Given this list of marker genes GYPC, CCL1, MS4A6A, MTMR14 (myotubularin related protein 14), GPRIN1, PERP, APBB2, CCNL1, AFF1, ATF3, LRRC23, CHMP2A, KATNBL1, MITD1, OTUD7B, PDZK1 (NCBI Gene Id 96133), GRB2, HMGN5 (high mobility group nucleosome binding domain 5), SOD2, PRRT1, SLAMF1, PTPN11, LMAN1L, H2AC25, STXBP3 (syntaxin binding protein 3), ZNFX1, NUB1, UBL7, GTPBP2, TLCD4, SAMSN1, SLC22A3, IER5, TXK, ZDHHC5, SLC8A2, NOTCH2, PFN3, GUCA1A, CD200, GBP7, COL5A3, GINM1, SFTPA1, DUSP11, VSX1, MARK4, HDHD2, UPF2, TRMT1L, ATP1B2, ADRA1A, G3BP2, ASB16, ALPK2, RUSC2, TXNL1, SPTLC2, ELL2, ZNF18, TDRD7, CD38, RPS6KA2 (NCBI Gene Id 6196), CST7, ME1, FBLN5, TANC1, ARF4, ITGA4, CLCN5, PHC2, TLX2, TNFRSF1A, PRDX5, TSPAN33, PIK3AP1, COX17, MYBL1, GABRR1, MFSD1, LDLR, CHTOP, PHGR1, ZNRF1, PI4K2A, DNER, BCKDHB, PRRC1, RIBC2, FBXW11, OAS2, ELOC, BHLHA15, CCDC120, DNAJC21, TTI2, MYD88, DSCAML1, ETNK1, NID1, KEAP1, DLX1, DNAJB11, HOXA5, KATNA1, EIF2S2, GAPDHS, KTN1, ACTN1, IDO2, IL10RB, HOXA11, NAA11, PDE4B, VCAN, IL23A, RUFY3, PIP5K1B, EYA4, CHD1, SIX1, KDR, PRKD1, RAB33B, GBP4 (NCBI Gene Id 115361), CBLN1, CHM, TNFRSF8, SLITRK1, PLCL2, IFNAR2, USP15, CLN5 (NCBI Gene Id 1203), STARD5, POGLUT1, LCE2B, MAGEA11, CDH13, MTHFD2 (methylenetetrahydrofolate dehydrogenase (NADP+ dependent) 2, methenyltetrahydrofolate cyclohydrolase), BST2, NFATC2IP, DLL4, SERTAD1, PRPF38A, PTPN13, NFKB1, LCE3B, IL18, PTPRE, CPSF2, PLEKHA6, MMP14, SFRP1, ELAPOR1, WASHC4, PALLD, SLC17A1, PLAA, LY6G6D (lymphocyte antigen 6 family member G6D), CSF1, PML, SUZ12, NMD3, ADHFE1, FOXP1, OSTF1, SPAG7, GLYCTK, MACROD2, IL1RN, PPP1R2P1, RNFT1, TXN, LIN9, PAWR, PSMA2, DDA1, BCL9, TUT1, TGM2, BFAR, CD47, DRC3, C1QL3, HNRNPD, CPD, CCNB3 (cyclin B3), IGBP1, TBK1, FRMD6, ZNG1B, PYY, CUTC, TAB2, CLDND1, SNX10, KANSL1L, PTGES, GLB1L, NAMPT, here is a description of the gene set: studied in species Homo sapiens Genes down-regulated in comparison of control dendritic cells (DC) at 4 h versus those stimulated with CpG DNA (TLR9 agonist) at 4 h. from publication Amit I, Garber M, Chevrier N, Leite AP, Donner Y, Eisenhaure T, Guttman M, Grenier JK, Li W, Zuk O, Schubert LA, Birditt B, Shay T, Goren A, Zhang X, Smith Z, Deering R, McDonald RC, Cabili M, Bernstein BE, Rinn JL, Meissner A, Root DE, Hacohen N, Regev A (PMID 19729616) mouse primary BMDCs were stimulated with tlr ligands and gene expression changes were profiled on Affymetrix arrays Human Gene Set: GSE17721_CTRL_VS_CPG_4H_BMDC_DN